The following is a description of a gene set: Human Gene Set: REACTOME_GLYCOGEN_METABOLISM studied in species Homo sapiens Glycogen metabolism, and this is the list of marker genes: UGP2, PPP1R3C, GYG2, PYGL, GYG1, PYGM, EPM2A, PYGB, GYS1, AKR1E2, CALM1, UBC, UBA52, AGL, PHKA1, NHLRC1 (NHL repeat containing E3 ubiquitin protein ligase 1), PHKA2, PHKG2, GBE1, PHKG1, PHKB, PGM1, RPS27A, GYS2, UBB, GAA